Given this list of marker genes Gnb3, Atg14, Cidec (NCBI Gene Id 14311), Cps1, Nkx2-3 (NCBI Gene Id 18089), Aadac, Dbi, Mfsd2a, Scarb1, Pnpla5, Lpin1, Lmf1, Mboat7, Scd1, Cideb, Pank2, Acsl6, Tnxb, Pnliprp2, Ptpn11, Gk2, Sorl1, C3, Mogat2, Tbl1xr1, Gk, Lipa, Ces1g, Apoh, Cav3, Cav1 (NCBI Gene Id 12389), Pck1, Plin5, Gpat4, Rbp2, Kat5, Esr1, Lpgat1, Nr1h4, Apoc3, Tcf7l2, Cdk8, Apoc2l, Mttp, Nr1h3, Blvra, Gpam, Fitm2, Insig1, Pnliprp1, Slc27a5, Angptl3, Ddhd2, Apob, Apoc2, Lpl, Lpin2, Gk5, Lipg, Apoc1, Mogat1, Cat, Srebf1 (NCBI Gene Id 276754), Sel1l, Lipc, Pik3cg, Acsl4, Agmo, Apoa5, Mir423, Apoa4, Thrb, Sik1, Pck2, Fgf21, Gpat2, Gykl1 (NCBI Gene Id 14625), Gpr82, Slc22a4, Thrsp, Pnpla2, Il6st, Gpx1, Agpat2, Apof, Apobr, Cnep1r1, Lpin3, Cyp2e1, Ccnc, Tmem68, Plb1, Pnlip, Lipe, Plaat3, Rgn, Gpat3, Pnpla1, Tmx1, Pcsk9, Apoe, Apobec1, Abhd5, Acsl1, Dgat2, Sirt1, Pnpla3 (patatin-like phospholipase domain containing 3), Gpld1, Ldlr, Gpihbp1, Slc37a4, Nr1h2, G6pc1, Daglb, Mgll, Cpt1a, Insig2, Serpina12, Dgat1, Acsl5, Slc27a1, Ctdnep1, here is a description of the gene set: Mouse Gene Set: GOBP_TRIGLYCERIDE_METABOLIC_PROCESS studied in species Mus musculus The chemical reactions and pathways involving triglyceride, any triester of glycerol. The three fatty acid residues may all be the same or differ in any permutation. Triglycerides are important components of plant oils, animal fats and animal plasma lipoproteins.